The following is a description of a gene set: Human Gene Set: GOBP_NEGATIVE_REGULATION_OF_CYTOKINE_PRODUCTION_INVOLVED_IN_INFLAMMATORY_RESPONSE species: Homo sapiens Any process that stops, prevents or reduces the frequency, rate or extent of cytokine production involved in inflammatory response., and this is the list of marker genes: MIR93, HMOX1, MIR98, EZH2, MIR135A1, ZC3H12A, MIR222, MEFV, MIR221, MIR338, NFKBIA, EXTL3, STAT3 (signal transducer and activator of transcription 3), TREM2, PSG9, NFKB1, MIR16-1, NLRC3, F2, MIR125A, PDCD4, PPARA, ABCD1, MIR146A, EPHB2, PRKCA, CHRNA7, PLA2G10, MIR203A (microRNA 203a), LILRB4, MIR140, JAK2, APOD, SIRPA, RELA, MACIR, ADCY7, SPINK7, ABCD2, CHID1, APPL2, PYCARD, MIR26A1, MIR136, MIR378A, ZFP36, IKBKB, NLRP7, CUEDC2, MIR129-1, IL1R2